Given this list of marker genes US30, US2, DYNC1I1, US33A, NUP155, UL94, gB, ITGB1, US9, UL78, RANBP2, H4C1, H2AC11, UL84, UL99, UL69, NEC2, TUBB8B, CVC2, UL111A, US22, H2BC15, NUP62, UL35, UL102, TBL1X, TUBA4B, MCP, DYNC1I2, NUP210, Hh5 strain Merlin complete genome, TUBB6, NUP133, US8, POM121C (POM121 transmembrane nucleoporin C), ELK1, UL32, TRS1, RL10, UL122, UL123, UL119/UL118, NCOR2, UL24, UL11, UL17, UL47, TUBA1B, NUP98, NUP42 (nucleoporin 42), UL104, US28, SCP, UL112/UL113, H2AC1, TRX2, AAAS, RBBP7, NUP160, UL71, POM121, H3C1, NUP43, UL43, TUBA3C, TPR, UL132, UL96, UL36, TUBA4A, H2BC4, SEH1L, NEC1, UL4, UL133, SEC13, TUBA3E, NFKB1, UL25, UL131A, US17, US19, UL23, H2BC14, EGFR, US13, UL13, NUP35, UL34, H2AC7, H3C15, H2BC1 (NCBI Gene Id 255626), US12, TUBA1A, PML, gH, TUBB4A, TUBB4B, DYNC1LI1, US3, US18, H2AC21, TRX1, DAXX, UL37, US23, H2AC6, US27, UL138, UL26, US34A, DYNC1H1, US14, TRIM28, US11, UL82, H2AC18, CVC1, TBL1XR1, NUP88, CBX1, RAE1, UL88, TUBB8, H2AC12, UL98, gM, TUBB3, UL97, TUBAL3, H2BC3, UL16, GPS2, UL95, NUP205, H2BC17, H2AC25, EZH2, H2AC20, TUBA8, NUP214, NUP153, UL79, NDC1, TUBB2B, UL114, DYNLL2, UL130, NUP93, NUP37, UL83, NUP58, H2BC21, UL76, TUBB1, UL124, UL74, SUZ12, gN, H2BC12, DYNLL1, US10, UL21A, NUP54, H2BC5, US20, HDAC3, H2BC18, UL27, RBBP4, H2BC13, TUBA3D, NCOR1, DUT, H2AC14, RNA4.9, TUBA1C, TUBB2A, NUP107, RL1, HELI, US34, H2BC11, NUP85, CREB1, NUP50, UL38, UL44, NUP188, US16, H2BC9, UL48, EED, DYNC1LI2, UL103, H2BC26 (NCBI Gene Id 128312, H2B clustered histone 26), gL, UL5, UL54, DBP, IRS1, RIR1, US24, RL11, US26, H2AC4 (H2A clustered histone 4), here is a description of the gene set: Once in the cytoplasm the capsid and tegument proteins are free to interact with host proteins. The capsid travels to the nucleus, where the genome is delivered and circularized. Tegument proteins regulate host cell responses and initiate the expression of viral I immediate early genes. This is followed by the expression of delayed early genes. Reactome Pathway: HCMV Early Events part of: HCMV Infection studied in species Homo sapiens